Given this list of marker genes SPR, LYPLA1, DDAH1, AKT1, CAV1, NOS3, HSP90AA1, CYGB (NCBI Gene Id 124510), ZDHHC21, NMT1, CALM1, NMT2, CYB5B (NCBI Gene Id 80777), here is a description of the gene set: eNOS activity is regulated by numerous post-translational modifications including phosphorylation and acylation, which also modulate its interactions with other proteins and its subcellular localization.<p>In general, following myristoylation and palmitoylation, eNOS localizes to caveolae in the plasma membrane, where in resting cells, it is bound to caveolin and remains inactive. Several agonists that raise intracellular calcium concentrations promote calmodulin binding to eNOS and the dissociation of caveolin from the enzyme, leading to an activated eNOS-calmodulin complex.<p>Phosphorylation plays a significant role in regulating eNOS activity, especially the phosphorylation of Ser1177, located within the reductase domain, which increases enzyme activity by enhancing reductase activity and calcium sensitivity. In unstimulated, cultured endothelial cells, Ser1177 is rapidly phosphorylated following a variety of stimuli: fluid shear stress, insulin, estrogen, VEGF, or bradykinin. The kinases involved in this process depend upon the stimuli applied. For instance, shear stress phosphorylates Ser1177 by activating Akt and PKA; insulin activates both Akt and the AMP-activated protein kinase (AMPK); estrogen and VEGF mainly phosphorylate eNOS via Akt; whereas the bradykinin-induced phosphorylation of Ser1177 is mediated by CaMKII. When Ser1177 is phosphorylated, NO production is increased several-fold above basal levels.<p>The phosphorylation of a threonine residue (Thr 495), located in the CaM binding domain, is associated with a decrease in eNOS activity. When this residue is dephosphorylated, substantially more CaM binds to eNOS and elevates enzyme activity. Stimuli associated with dephosphorylation of Thr495 (e.g., bradykinin, histamine, and Ca2+ ionophores) also increase Ca2+ levels resulting in the phosphorylation of Ser1177.<p>Additional phosphorylation sites, such as Ser114 and Ser633, and tyrosine phosphorylation have all been detected, but their functional relevance remains unclear. It is speculated that the tyrosine phosphorylation of eNOS is unlikely to affect enzyme activity directly, but more likely to impact the protein-protein interactions with associated scaffolding and regulatory proteins. part of: Metabolism of nitric oxide: NOS3 activation and regulation species: Homo sapiens Reactome Pathway: eNOS activation